Given this list of marker genes TCN2, LIG4, FMR1, FANCG, UHRF1, SMARCE1, DNAJC21, AKT1, BAP1 (NCBI Gene Id 8314), MAD2L2, CDCA7, FANCI, RNF168, NF2 (NF2, moesin-ezrin-radixin like (MERLIN) tumor suppressor), FANCF, XRCC2, XRCC4, RFWD3, DCLRE1B, SLX4, HELLS, CENATAC, FANCM, FANCD2, TMEM185A, FANCA, NBN, RAD50, TRAF7, ERCC4, MCM4, TERT, BRCA1, BRCA2, ATM, UBE2T, SMARCB1, RAD51, RMRP, FANCB, SUFU, BRIP1, FANCL, SMO, FANCC, TOP3A, ZBTB24, BLM, PALB2, FANCE, PDGFB (NCBI Gene Id 5155), RAD51C (RAD51 paralog C), PIK3CA, DNMT3B, COX4I1, here is a description of the gene set: Human Gene Set: HP_ABNORMALITY_OF_CHROMOSOME_STABILITY Abnormality of chromosome stability species: Homo sapiens A type of chromosomal aberration characterized by reduced resistance of chromosomes to change or deterioration.